The following is a description of a gene set: Genes up-regulated in comparison of control dendritic cells (DC) at 8 h versus those stimulated with CpG DNA (TLR9 agonist) at 8 h. mouse primary BMDCs were stimulated with tlr ligands and gene expression changes were profiled on Affymetrix arrays from publication Amit I, Garber M, Chevrier N, Leite AP, Donner Y, Eisenhaure T, Guttman M, Grenier JK, Li W, Zuk O, Schubert LA, Birditt B, Shay T, Goren A, Zhang X, Smith Z, Deering R, McDonald RC, Cabili M, Bernstein BE, Rinn JL, Meissner A, Root DE, Hacohen N, Regev A (PMID 19729616) Human Gene Set: GSE17721_CTRL_VS_CPG_8H_BMDC_UP studied in species Homo sapiens, and this is the list of marker genes: TM9SF2, MCEE, SPTBN1 (spectrin beta, non-erythrocytic 1), GLUL, CORO1A, HEXIM1, PRPS2, FKBP4, TUBA1A, LTC4S, MED22, CDADC1, NUDCD1, PLXNB2, AP1G2, REV3L, FAM117A, XPR1, DGAT1, ELOVL5, HOXA2, RPL38, LCMT1, NEU1, DHX16, TFCP2, TECPR1, CEACAM21, LDLR, CDC25B, KIF20A, TFRC, ABCB8, EEPD1, BNIP3L, CYP51A1, LTBP3, RBL2, SLC16A6, METTL18, SNAPC2, MIDN (NCBI Gene Id 94034), EBP, IP6K1, ACRBP, FAM53A, MYL12B, ORC1, SNX14, CCNB2, PGD, ZNF106, ANKH, EFL1, HMBS, GYS1, SMPD2, PRKCD, TUSC2, RHOJ (ras homolog family member J), KIAA0930, CTNNA1, CCNQ, IVD, TMEM14C, FDPS, RASSF5, LSM3, SC5D, SMARCAD1 (SWI/SNF-related, matrix-associated actin-dependent regulator of chromatin, subfamily a, containing DEAD/H box 1), PCYOX1, NHP2, GPAM, NAGK, HLA-DMA, TRIM39, ABCA2, NAA60, MOS, RPRD2, TPRA1, MPHOSPH9, RASSF3, MRPL2, NCBP1, PLEKHA1, MRPS23, PADI2, ACOT11, FAM162A, SKI, ADCY7, CTNNBL1, CIITA, RAB7A, STRBP, CENPV, RBM5, SPO11, HMGB2, CCDC28A, CAVIN3, RNASE4, CCR6, PABPC4, SEPTIN8, UXT, SLC39A4, KLRD1, AGL, TRIM3, PCK1, SEPTIN2, SMARCD2, LEPROT, CD79A, MTARC2, TMEM51, CDC25C, LIMA1, RPL6, NR2F6, MINDY1, SMIM14, MTFMT, C2CD2L, ATP5IF1, NDUFAB1, MGST2, FUOM, MRPS25, CIDEB, BCL2L11, CNOT6L, CDKAL1, PDLIM2 (NCBI Gene Id 64236), MRPL3, PTPRO (protein tyrosine phosphatase receptor type O), PLPP2, SYNPO, RPS6KB2, MOSPD2, PHKA2, CFAP68, PLD1, HNRNPH3, MDP1, CPPED1, MTMR1, WDR45, TMUB2, ADAM15, HEPACAM2, COMMD5, SLC25A13, CERS5, TM9SF3, CEBPZOS, NQO2, OAZ2, RRP12, PARVG, HMGCL, RETREG1 (reticulophagy regulator 1), OSBPL2, C1orf54, CD93, GAK (NCBI Gene Id 2580), TRMT1, ZNF124, ELP2, PEPD, HNRNPU, RAC1, FBXO8, IQGAP3, NGRN (NCBI Gene Id 51335), RP9, ZFYVE21, GALT, HP1BP3, TGFBR1, PIP4K2A, LUC7L3, DGLUCY, H1-10, MED25, EDEM3, PLA2G15, CD300C, SIN3A, DHX36, MIGA2, SOBP, ACAT1, TSPAN5, HNRNPL, SCN4A, ALDH1L1, TMEM216